Given this list of marker genes Ldlrap1, Gpihbp1, Trem2, Anxa2, Lipg, Gpld1, here is a description of the gene set: Mouse Gene Set: GOBP_POSITIVE_REGULATION_OF_LIPOPROTEIN_PARTICLE_CLEARANCE Any process that increases the rate, frequency, or extent of lipoprotein particle clearance. Lipoprotein particle clearance is the process in which a lipoprotein particle is removed from the blood via receptor-mediated endocytosis and its constituent parts degraded. species: Mus musculus